The following is a description of a gene set: studied in species Homo sapiens Human Gene Set: HP_ABNORMAL_ERYTHROID_LINEAGE_CELL_MORPHOLOGY Abnormal erythroid lineage cell morphology An anomaly of erythroid lineage cells, that is, of the erythropoietic cells in the lineage leading to and including erythrocytes., and this is the list of marker genes: HSCB, SLC19A1, DDX41, HSPA9, MYSM1, ERBB3, UBA1, KIF23, SF3B1, SLC30A7, RACGAP1, TET2, CDIN1